The following is a description of a gene set: Genes positively differentially expressed in cell type: CD4+ T cell upon treatment with cytokine: OSM in mouse lymph nodes in vivo. from publication Cui A, Huang T, Li S, Ma A, Pérez JL, Sander C, Keskin DB, Wu CJ, Fraenkel E, Hacohen N (PMID 38057668) Cytokines mediate cell-cell communication in the immune system and represent important therapeutic targets. A myriad of studies have highlighted their central role in immune function, yet we lack a global view of the cellular responses of each immune cell type to each cytokine. To address this gap, the authors created the Immune Dictionary, a compendium of single-cell transcriptomic profiles of more than 17 immune cell types in response to each of 86 cytokines (>1,400 cytokine-cell type combinations) in mouse lymph nodes in vivo. A cytokine-centric view of the dictionary revealed that most cytokines induce highly cell-type-specific responses. For example, the inflammatory cytokine interleukin-1β induces distinct gene programmes in almost every cell type. A cell-type-centric view of the dictionary identified more than 66 cytokine-driven cellular polarization states across immune cell types, including previously uncharacterized states such as an interleukin-18-induced polyfunctional natural killer cell state. Mouse Gene Set: CUI_T_CELL_CD4_OSM_RESPONSE_UP studied in species Mus musculus, and this is the list of marker genes: Ndrg3, Ddit4, Ly6a, Zbp1, Kbtbd11, Rapgef6, Treml2, Serinc3, Bcl3 (B cell leukemia/lymphoma 3), Myl12b, Socs3, Ccnd3, Pdcd4, Apobec3, Ly6e, Dtx1, Igfbp4, Rcsd1, Uba52